The following is a description of a gene set: Human Gene Set: REACTOME_ACTIVATED_NOTCH1_TRANSMITS_SIGNAL_TO_THE_NUCLEUS species: Homo sapiens Activated NOTCH1 Transmits Signal to the Nucleus, and this is the list of marker genes: DNER, ADAM10, NUMB, JAG1, RPS27A, APH1B, PSEN1, APH1A, UBA52, PSEN2, DTX2, DLK1, NEURL1B, ADAM17, UBB, NOTCH1, MIB1, DLL4, NCSTN, ARRB2, ARRB1, DTX1, CNTN1, JAG2 (NCBI Gene Id 3714), ITCH, DLL1, MIB2, UBC, DTX4, PSENEN (presenilin enhancer, gamma-secretase subunit), NEURL1